Given this list of marker genes SFTPC, SFTPB, NAPSA, IL12A, PGA4, CTSH, PGA3, PGA5, IL12B, here is a description of the gene set: Human Gene Set: GOCC_LATE_ENDOSOME_LUMEN The volume enclosed by the membrane of a late endosome. studied in species Homo sapiens